The following is a description of a gene set: Genes predicted to be targets of miRBase v22 microRNA hsa-miR-5687 in miRDB v6.0 with MirTarget v4 prediction scores > 80 (high confidence targets). studied in species Homo sapiens Human Gene Set: MIR5687 from publication Chen Y, Wang X (PMID 31504780), and this is the list of marker genes: CAPZA1, PDCD6, SP2, RRAGC, C1GALT1C1, GOLM2, MCM9, HTR4 (5-hydroxytryptamine receptor 4), HRNR, MORF4L2, FOXO1, CYP3A43, SP8, GZF1, BTBD3, AXL, PDE7A, CTNND2 (NCBI Gene Id 1501), WASHC5, SIM2